Given this list of marker genes PTPN11, PIK3CD, NFIX, POGZ, CLIC2, CBL, LIMK1, ALOX12B, BUD23, HSPG2, SCNM1, OCRL, ZSWIM6, HECW2, FBN1, H3-3A, FUCA1, METTL27, THOC6, ANTXR1, B9D1, CHAMP1, ACER3, NCF1, WDR35, RNF135, BCL11A, SMARCA2, NRAS, DOCK7, ASPRV1, PTH1R, ZEB2, CDT1, SOS2, QRICH1, AHDC1, GTF2IRD2, GNAI1, ADNP, BDNF, RFC2, MDH1, KIF15, FOXC1, MSX1, CDH11, TAF4, GJA5, SMS, CYP4F22, GTF2IRD1, IFT56, STRADA, TMEM270, FRMD4A, SCARF2, SPRED2, PLXND1, IDS, RAF1, NIPAL4, KNSTRN, SMARCD1, SOX4, SMARCE1, CHD2, SOX11, POU4F1, EDA (NCBI Gene Id 90878), PACS2, REV3L, FGD1, PIGN, MECP2, TFAP2A, CAMTA1, FHL1, TBL1XR1, RAB3GAP2, SHOC2, TFAP2B, RET, KIF11, DHX30, ECM1, ASXL3, IRX5, EDARADD, HUWE1, PHGDH, ESAM, WT1, KIFBP, WDR19, CLIP2, ADAMTS2 (NCBI Gene Id 9509), UBAP2L, KCNH1, NEU1, KAT5, WDR26, MYCN, IFT52, FOXG1, ATP6V1B2, ELN, CUL4B, HRAS, CHN1, MED12L, GLI2, SALL4, DYRK1A, CDKL5, ABCC9, SMARCB1, HS2ST1, AFF3, TMEM53, ERCC2, MED13L, GRHL3, KCNN3 (potassium calcium-activated channel subfamily N member 3), SMARCA4, PUS7, BAZ1B, ATRX (NCBI Gene Id 6475), LTBP1, HDAC4, EDNRA, RHOBTB2, TMEM147, HGSNAT, FLNA, MCOLN1, AGA, CA2, EHMT1, LIPN, IGF1R, TNPO2, CUL7, EDAR, SNRPN, GBA1, IDUA, RRAS, ABHD5, SMC5, POMGNT1, ERCC5, LTBP3, SCN1A, DENND5A, SPECC1L, PSMB8, GLA, CCDC8, INSR, MBD5, ZBTB20, KMT2D, RRAS2, SYNGAP1, SDR9C7, EBF3, PAX6 (NCBI Gene Id 5080), EDA2R, FBXL4, SLC2A1, SLC25A24, ERCC6, RPL10, STX1A, SETD1B, ARID1B, KRAS, RPS23, FKBP6, DEAF1, DNAJC30, MRAS, IFT43, NEXMIF, TGM1 (transglutaminase 1), KMT2C, BCAS3, TASP1, YY1, OBSL1, ARID2, IRF6 (interferon regulatory factor 6), FTSJ1, RAB3GAP1, GTF2I, GJA8, ACBD6, DRG1, UGDH, PIGL, KANSL1, SRCAP, ARID1A, MED25, MLXIPL, VPS37D, MAFB, AP2M1, BMP2, PITX2, MGAT2, FBXO11, MED12, EEF1A2, SULT2B1 (sulfotransferase family 2B member 1), DPF2, RIT1, RASA2, NAGA, ALOXE3, RPS6KA3, SMARCC2, RNU4-2, AMER1, NANS, PCDHGC4, SMG9, SOS1, GNS, RBMX, KCNMA1, TBC1D24, TFE3, IFT122, MYO18B, PPP1CB, EIF4H, SIN3A, LZTR1, TBL2, KDM6A, ERCC1, COL11A1, ABCA12, SLC6A1, here is a description of the gene set: species: Homo sapiens An abnormality of the lower lip. Abnormal lower lip morphology Human Gene Set: HP_ABNORMAL_LOWER_LIP_MORPHOLOGY